Given this list of marker genes PAX3, DDB1, HUWE1, PPP1R12A, MKS1, CSNK2A1, SIX2, CDC42BPB (CDC42 binding protein kinase beta), COLEC11, COLEC10, MASP1 (NCBI Gene Id 5648), KAT6B, EBF3, FOXL2, PEX6, here is a description of the gene set: Epicanthus inversus studied in species Homo sapiens Human Gene Set: HP_EPICANTHUS_INVERSUS A fold of skin starting at or just below the medial aspect of the lower lid and arching upward to cover, extend in front of and lateral to the medial canthus.